Given this list of marker genes AGBL2, VAX1, PDZRN4, IGSF1, CCER1, ADCYAP1, BMI1, COL12A1, LIF (NCBI Gene Id 3976), EOMES, TMSB4XP8, KLF14, FOXP1, TMSB4XP6, NHLH2, TMSB4XP4, RPL27A, PRDM13, PBX2, JAKMIP2, CKMT2, PRDM1, CSNK1A1, ESRRG, ANGPT1, CPNE1, CUZD1, TMEM62, TMEM255A, OSBPL6, IKZF2, CLU, DLG3, ANKS1B, ABLIM1, TBX4, TPM3, STAG2, SOX14, PDP1, ASB4, MPPED2, PPP2R5C, SLF1, TMSB4XP1, MCUB, EML4, SIAH3, RUNX1T1 (RUNX1 partner transcriptional co-repressor 1), SLITRK1, SIAH1, ZBTB25, BAZ1A, TRMT10A, EGLN1, CHODL, OMG, ZNF281, TBX19, FOXF2, ACVR2A, TGIF1, PENK, ADAMTS6, OLFML3 (NCBI Gene Id 56944), here is a description of the gene set: Genes having at least one occurrence of the highly conserved motif M161 TTANWNANTGGM in the regions spanning 4 kb centered on their transcription starting sites. The motif does not match any known transcription factor binding site. studied in species Homo sapiens from publication Xie X, Lu J, Kulbokas EJ, Golub TR, Mootha V, Lindblad-Toh K, Lander ES, Kellis M (PMID 15735639) Comprehensive identification of all functional elements encoded in the human genome is a fundamental need in biomedical research. Here, we present a comparative analysis of the human, mouse, rat and dog genomes to create a systematic catalogue of common regulatory motifs in promoters and 3' untranslated regions (3' UTRs). The promoter analysis yields 174 candidate motifs, including most previously known transcription-factor binding sites and 105 new motifs. The 3'-UTR analysis yields 106 motifs likely to be involved in post-transcriptional regulation. Nearly one-half are associated with microRNAs (miRNAs), leading to the discovery of many new miRNA genes and their likely target genes. Our results suggest that previous estimates of the number of human miRNA genes were low, and that miRNAs regulate at least 20% of human genes. The overall results provide a systematic view of gene regulation in the human, which will be refined as additional mammalian genomes become available. Human Gene Set: TTANWNANTGGM_UNKNOWN